The following is a description of a gene set: species: Homo sapiens Human Gene Set: MODULE_300 Programmed cell death., and this is the list of marker genes: DUSP6, AHR, CD40, CD2, IL1B, TNFRSF25, TNFRSF1B, MAEA, ADRA1A, TRAF2, IL18, HTRA2, PDCD1, IL2RA, LTBR, TNFAIP3, DAPK1, P2RX1, NFKBIA, TRAF1, STAT1, DAP3, LY86, RIPK1, CDK11A, CRADD, CASP14, DAP, PEA15, CASP1, CD38, GPR65 (NCBI Gene Id 8477), CD14